The following is a description of a gene set: Human Gene Set: HP_CEREBRAL_VISUAL_IMPAIRMENT species: Homo sapiens A form of loss of vision caused by damage to the visual cortex rather than a defect in the eye. Cerebral visual impairment, and this is the list of marker genes: NAGA, SHANK3, SON, NEUROD2, ARHGDIA, ADARB1, CACNA1B, GRIN1, SLC25A19, MT-TW, MTHFS, SV2A (NCBI Gene Id 9900), CACNA1D, GAS1, ATN1, CHMP1A, GRM7, ITPR1, PARS2, RALGAPA1, SELENOI, COPB2, PGAP1, AHDC1, PHGDH, GRIK2, PIGS, MT-TV, AMPD2, POLG, MACF1, MT-TK, PIGT, SLC31A1, H3-3A, PPP3CA, DISP1, TBCK, AFG2B, DPM1, PIGY, MAPK8IP3, HK1, PET100, KIF5A, RAB18, CC2D2A, MT-TC, TSEN54, COG5, COQ4 (coenzyme Q4), GABRA2, FCSK, ZIC2, FGFR1, VPS51 (VPS51 subunit of GARP complex), YIF1B, TSEN34, PIGP, CLP1, NODAL, FBXW7, NR2F1, RAB3GAP1, GABRB1, COX6B1, CEP85L, NDUFAF1, POGZ, RAB3GAP2, ASNS, FGF12, VAMP2, PLCH1, STAG2, DLL1, LMNB1, NARS2, SEPSECS, MT-TS2, EMC1, FDFT1, SUOX, D2HGDH, SLC25A4, MT-TF, ADNP, CHKA, TIMM8A, FTH1, DOCK7 (dedicator of cytokinesis 7), PDSS2, NADK2, PTCH1, KIF1A, SLC25A1, TSEN2, CCDC47, TTI1, ARPC4, MT-ND1, RRM2B, TMEM237, SPTBN4, FOXH1, SHH, GLI2, TGIF1, AFG2A, CACNA1I, CDKL5 (NCBI Gene Id 6792), RNF13, CRIPTO, MT-TQ, TANGO2, POLG2, MT-CO3, SCN1A, PSMD12, PUM1, KMT2B, SCN3A, MT-TL1, EIF4A2 (eukaryotic translation initiation factor 4A2), GRIN2D, CHD3, MT-CYB, TRAF7, PRUNE1, CERT1, NEDD4L, PIGU, MT-ND6, PIGA, TSEN15, FGF8, MT-CO2, CDON, VPS11, TBC1D20, AFF3, SMC1A (NCBI Gene Id 8243), MT-CO1, CACNA2D1, KAT6A, CACNA1E, MT-ND5, DOHH, POLR3GL, CLCN4, TUBGCP2, STIL, TRAPPC12, FOXRED1, CPSF3, GLYCTK, PIGQ (phosphatidylinositol glycan anchor biosynthesis class Q), ADA2, TWNK, P4HTM, NUS1, BRAT1, GABRB2, HECW2, CLCN6, DTYMK, TRAPPC2L, BRAF, PPP2R1A, ST3GAL5, SIX3, SLC35A2, TELO2, TMEM53, SNRPN, RERE, GNB1, DIAPH1, CAMSAP1, PYCR2